Given this list of marker genes APOE, MIR20A, MECP2, TGFB1, MEOX2, MIR483, MIR15B, MIR101-1, MIR24-1, MAP2K5, THBS1, ANGPT2, NOTCH1, MMRN1, HMGB1, GDF2, PDCD10, MIRLET7A1, ACVRL1, MIR505, MIR640, MIR212, RGCC, MIR497, CARD10, MIR22, GADD45A, AGTR2, MIR2355, MIR133B, MIR424, MIR204, ANGPT4, MIR410, MIR92A1, MIR329-1 (NCBI Gene Id 574408), MIR26A1, MIR129-1, MIRLET7B, MIR137, MIR503, MIR200C, MIR10A, MIR29C, MIR146A, KLF4, MMRN2, ITGB1BP1, RHOA, MIR221, FGF2, HDAC5, MIR19B1, MIR16-1, ATP2B4, MIR132, SPRED1, MIR200B, PPARG, HRG, MIR206, MIR495, MIR199A1, JUP, MIR361, STARD13, MIR193A, TNF, MIR149, TBXA2R, MIR885 (microRNA 885), MIR196A1, MIR492, MEF2C, MIR15A, MIR494, MIR205, DLL4, CSNK2B, VASH1, MIR152, MIR320A, ROBO4, here is a description of the gene set: studied in species Homo sapiens Human Gene Set: GOBP_NEGATIVE_REGULATION_OF_BLOOD_VESSEL_ENDOTHELIAL_CELL_MIGRATION Any process that stops, prevents, or reduces the frequency, rate or extent of the migration of the endothelial cells of blood vessels.